Given this list of marker genes Mettl16 (methyltransferase 16, N6-methyladenosine), Pcif1, Cmtr2, Mettl8, Tmt1a2, Tmt1a, Mettl14, Tmt1a3, Nsun2, Cmtr1, Mettl1, Mettl3, Trmt61a, Nsun4, Rnmt (RNA (guanine-7-) methyltransferase), here is a description of the gene set: Mouse Gene Set: GOMF_MRNA_METHYLTRANSFERASE_ACTIVITY Catalysis of the transfer of a methyl group from S-adenosyl-L-methionine to a nucleoside residue in an mRNA molecule. studied in species Mus musculus